Given this list of marker genes Grn, Antxr1, Nr1h2, Plin5, Foxj1, Aph1a, Ctsh, Itgb1, Ccl26 (NCBI Gene Id 541307), Arhgap24, Tmem106b, Ang4 (NCBI Gene Id 328486), Scrib, Apoa4, Rhoa, Rasgrp1, Ccl11, Ppargc1b, Mapre2, Calm2, Cav2, Tgm2, Rgs16, Ccn1, Arhgef7, Wnt4, Fgfr2, Ect2, Nedd9, Pin1, Mtss2, Tiam1, Cd200, Wdr41, Apoh, Apc2 (APC regulator of WNT signaling pathway 2), Bmp2, Cldn13, Zc3h15, Arhgef5, Apoa1, Rgs14, Tbc1d20 (NCBI Gene Id 98946), Vsir, Arhgef19, Crk, Rock1, Arhgap6, Lyn, C9orf72, Tbc1d30, Pnlip, Plek, Agtr1a, Slc27a4, Lars1, Rgs7, Sipa1l1, Srgap2, Rcn3, Gpihbp1, Prelid1, Rangap1, S100a10, Akt1, Gsk3b, Rab3gap1, Snx13, Lmf1, Lims1, Als2, Smcr8, Rapgef6, Prkcd, Dock10, Vav1, Npnt, Arhgap42, Dennd1b, Rasgrp2 (RAS, guanyl releasing protein 2), Sfrp2, Tbc1d2, Calm3, Rapgef1, Efna3, Rhog, Ptk2b, Usp17le, Ralgapa2, Wrn, Rcc2, Kalrn, Arhgef16, Cldn3, Mtmr9, Rsu1, Hras, Apoa5, Agrn (NCBI Gene Id 381587), Wnt5a, Vcp (NCBI Gene Id 269523), Ezh2, Sema4d, Stat3, Chp2, Rap1gap, Thy1, Rap1a, Ifng, Sgsm2, Myo9b, Ripk3, Mef2c, Rgma (NCBI Gene Id 244058), Tank, Evi5, Dock11, Sgsm3, Ralbp1, F2r, Rgp1, F2rl1, Tbc1d7, Pin1rt1, Arhgap35, Rps3, Ccdc125, Cxcl13, Crkl, Ang6, Ang, Arap1, Map4k4, Prss22, Plaa, Rack1, Rtn4r, Bcar3, Usp6nl, Rgs6, Cd40 (NCBI Gene Id 98930), Pkp4, Nf1, Akt2, Ntrk1, Grhl3, Efna1, Aph1c, Psenen, Rgs10, Avpr1b, Adcyap1, Calm1, Ndel1, Ccl19, Gnb5, Abr, Ralgapb, Epha1, Rasgrf1, Ccl5, Snx9, Epha2, Rapgef3, Plxnb1, Dvl2, Dennd1a, Coro1c, Ager, Psap, Prtn3, Odam, Cldn4, Dock8, Ralgapa1, Pip5k1a, Ccl24, Epha4, Pla2g5, Tax1bp3, Itga6, Apoc2, Rgs1, Ntf3, Fgfr3, Aph1b, Dock9, Agtr1b, Evi5l, Arhgef10, Ccr7, Rgs8, Mmut, Wnt11, Rab11fip2, Ddrgk1, Snx18, Arhgap11a, Mex3b, Rhoc, Sh3bp1, Apoc2l, Ang5, Tsc1, Pcna, Net1, Dvl3, Asap3, Ang2, Nr1h3, Prex1, Ncstn, Dock7, Ric1, Fermt2, Mbp, Gpr65, Rapgef2, Ntrk3, Syde1, Bcr, Gpld1, here is a description of the gene set: Any process that activates or increases the frequency, rate or extent of hydrolase activity, the catalysis of the hydrolysis of various bonds. species: Mus musculus Mouse Gene Set: GOBP_POSITIVE_REGULATION_OF_HYDROLASE_ACTIVITY